The following is a description of a gene set: Mouse Gene Set: GOBP_REGULATION_OF_PHOSPHATIDYLINOSITOL_DEPHOSPHORYLATION studied in species Mus musculus Any process that modulates the frequency, rate or extent of the chemical reaction involving the removal of one or more phosphate groups from a phosphatidylinositol., and this is the list of marker genes: Mtmr4, Mtmr2, Mtmr3, Mtmr9, Chrm5, Mtmr1